Given this list of marker genes BDNF, HDAC1, SIN3A, MECP2, here is a description of the gene set: Missense mutations in the methyl-CpG binding domain (MBD) of methyl-CpG-binding protein 2 (MECP2), spanning amino acids 90 to 162, negatively affect the binding ability of MECP2 to methylated DNA. studied in species Homo sapiens part of: Loss of function of MECP2 in Rett syndrome Reactome Pathway: Loss of MECP2 binding ability to 5mC-DNA